The following is a description of a gene set: Mouse Gene Set: GOBP_POSITIVE_REGULATION_OF_ANTIMICROBIAL_HUMORAL_RESPONSE species: Mus musculus Any process that activates or increases the frequency, rate, or extent of an antimicrobial humoral response., and this is the list of marker genes: Il17a, Pgc, Klk5, Nod2, Il17f, Klk7, Acod1